Given this list of marker genes SPHK2, TCIRG1, PHB2, IL13, COX17, ATP4A, PPIF, here is a description of the gene set: studied in species Homo sapiens Human Gene Set: GOBP_REGULATION_OF_PROTON_TRANSPORT Any process that modulates the frequency, rate or extent of proton transport into, out of or within a cell, or between cells, by means of some agent such as a transporter or pore.